Given this list of marker genes AREG, SOS1, EGF, TGFA, GRB2, SHC1, EREG, KRAS, NRAS, EPGN, EGFR, HRAS, HBEGF, BTC, here is a description of the gene set: Human Gene Set: REACTOME_SHC1_EVENTS_IN_EGFR_SIGNALING SHC1 events in EGFR signaling studied in species Homo sapiens